Given this list of marker genes Smad6, Hey1, Bmp4, Stra6 (stimulated by retinoic acid gene 6), Smad2, Nos3, Adamts5, Notch2 (NCBI Gene Id 99749), Heyl, Jag1, Tbx20, Robo1, Hey2, Robo2, Tgfb2, Nfatc1, Notch1, Adamts19, Gja5, Slit2, here is a description of the gene set: species: Mus musculus Mouse Gene Set: GOBP_PULMONARY_VALVE_MORPHOGENESIS The process in which the structure of the pulmonary valve is generated and organized.